The following is a description of a gene set: RHO GTPases activate PKNs Mouse Gene Set: REACTOME_RHO_GTPASES_ACTIVATE_PKNS studied in species Mus musculus, and this is the list of marker genes: Ywhab, Pkn1, Ppp1r14a, Pkn2, Rhoa, Ppp1cb, Sfn (stratifin), Rhoc, Ncoa2, Ppp1r12a, Ywhae, Pkn3, Ar, Rhob, Ywhah, Cdc25c, Ywhag, Pdpk1, Ywhaz, Ywhaq, Ppp1r12b, Rac1